The following is a description of a gene set: Human Gene Set: GOCC_DYNEIN_COMPLEX Any of several large complexes that contain two or three dynein heavy chains and several light chains, and have microtubule motor activity. studied in species Homo sapiens, and this is the list of marker genes: DNAH7, DNAI7, DYNC2I1, NUDCD3, CFAP70, DYNLT4, DNAH5, DNHD1, DYNC2I2, DNAI3, DYNC1H1, DNAL1, DNAH17, DNAH11, DNAI4, DYNLT2, NME8, ODAD1, DNAI1, CCDC65, TPR, DNAI2, DYNC1I1, DNAH10, DCTN2, DYNLT1, DNAH1, DYNC1LI2, DNAH12, DNAH14, DNAH3, DCTN4, DYNLT2B, DYNLRB2, DYNC2H1, DNAH6, DYNLT5, SNX4, CCDC103, DYNLL1, DNAH9, DNAH8, DISC1, DYNC2LI1, DYNLRB1 (dynein light chain roadblock-type 1), DYNLT3, DCTN1, DYNLL2, DNAL4, DYNC1LI1, DYNC1I2, DNAH2, DRC1, DNALI1